Given this list of marker genes Tex101, Emcn, Lalba, Esyt2, Bcl2a1d, Slc15a3, Slc31a2, Slfn4, Tlr2, Capn3 (NCBI Gene Id 98918), 4931439C15Rik, Cpd, C3, Clec5a, Bcl2a1b, Ackr1, Anxa4, Gstm3, Actn1, Gyg1, Cndp2, Cd44, Soat1, Slc30a6, Ccr1 (C-C motif chemokine receptor 1), Ceacam2, Cap1, Ren1, Csf2ra, Cnn2, Fpr1, Itgam, Ccr2, Alcam, Plgrkt, Plg, Il4i1, Cpne3, G6pdx, Reg3d, Plk3 (polo like kinase 3), Csta2, Npc1, Fcgr3, Gp5, Qsox1, Sat1, S100a11, Camp, Sirpa, Dop1b, Inhca, Rnase4, Msrb1 (methionine sulfoxide reductase B1), Anxa5, Plaur, Grina, Ccnd2, Gm9887, Fgr, Mapk3, Id2, Fcgr1, Cd209f, Mxd1, Antxr2 (NCBI Gene Id 79402), Zyx, Tecpr1, Nfam1, Septin5, Cd80, Apol9b, Fpr2, Rpe, Scarb2, Nos1, Boll, Glrx, Bcl2a1a, Rpl13, Tcl1, Stfa2, Cldn1, Cd52, Hebp1, Lcn2 (NCBI Gene Id 99344), Il1b, Pygl, Clec4n, Dab2, Stfa3, Nxpe4, Clec4a2, Cd33, Cybb, D730003K21Rik, Ctss, Pgd, S100a6, Nqo1, Dstn, Capg, 4930515L19Rik, Sgms2, Mug1 (NCBI Gene Id 17836), Ceacam1, Arhgef3, Pstpip2, Grn, Fth-ps2, C2, Edil3, Rack1, Il1rn, Edar, Tnfrsf1a, Klra2, Mcemp1, Vsir, Ccl6, Lasp1, F10, Clec4b1, Atp6v1b2, Hck, Abcd2, Itgb2 (integrin beta 2), Siglece, Cd68, Ereg, Mcl1, Wfdc21, Psg28, Olr1 (NCBI Gene Id 18374), Mpeg1, Trem2, Neat1, Pik3cb, Pira13, Trp53inp1, Fhad1, Glipr2, Pla2g2e, Mmp8, Tnnt3, Ccdc125, Stom, Itgax, Myo1b, Slfn3, Klhdc4, Abhd5, Trpm2, Cebpd, Upp1, Sp100, Tnf, Bbln, Lyzl1, Pira12, Atp6v1e1, Xdh, Gns, Rps17, Bcl2a1c, Anpep, Degs1 (NCBI Gene Id 98213), Lilrb4a, Slc6a6, Gsn, Slfn1 (NCBI Gene Id 20555), Il1r2, Tgfbi, Ugt2b37, Spaca7, Tyrobp, Serpinc1, Egr1, Aoah, 1700054A03Rik, Tifab, Slfn2, Hexb (hexosaminidase B), Hlx, H2-M9, Junb, C5ar1, Dgat2, Iqgap1, here is a description of the gene set: species: Mus musculus Genes defining differentiation potential of the bipotential myeloid cell line FDB. Mouse Gene Set: BROWN_MYELOID_CELL_DEVELOPMENT_UP from publication Brown AL, Wilkinson CR, Waterman SR, Kok CH, Salerno DG, Diakiw SM, Reynolds B, Scott HS, Tsykin A, Glonek GF, Goodall GJ, Solomon PJ, Gonda TJ, D'Andrea RJ (PMID 16769770) Mechanisms controlling the balance between proliferation and self-renewal versus growth suppression and differentiation during normal and leukemic myelopoiesis are not understood. We have used the bi-potent FDB1 myeloid cell line model, which is responsive to myelopoietic cytokines and activated mutants of the granulocyte macrophage-colony stimulating factor (GM-CSF) receptor, having differential signaling and leukemogenic activity. This model is suited to large-scale gene-profiling, and we have used a factorial time-course design to generate a substantial and powerful data set. Linear modeling was used to identify gene-expression changes associated with continued proliferation, differentiation, or leukemic receptor signaling. We focused on the changing transcription factor profile, defined a set of novel genes with potential to regulate myeloid growth and differentiation, and demonstrated that the FDB1 cell line model is responsive to forced expression of oncogenes identified in this study. We also identified gene-expression changes associated specifically with the leukemic GM-CSF receptor mutant, V449E. Signaling from this receptor mutant down-regulates CCAAT/enhancer-binding protein alpha (C/EBPalpha) target genes and generates changes characteristic of a specific acute myeloid leukemia signature, defined previously by gene-expression profiling and associated with C/EBPalpha mutations.